The following is a description of a gene set: Genes up-regulated in CD4 T helper cells (4h): Th0 versus TGFB1 and IL6. Despite their enormous importance, the molecular circuits that control the differentiation of Th17 cells remain largely unknown. Recent studies have reconstructed regulatory networks in mammalian cells, but have focused on short-term responses and relied on perturbation approaches that cannot be applied to primary T cells. Here, we develop a systematic strategy – combining transcriptional profiling at high temporal resolution, novel computational algorithms, and innovative nanowire-based tools for performing gene perturbations in primary T cells – to derive and experimentally validate a temporal model of the dynamic regulatory network that controls Th17 differentiation. The network is arranged into two self-reinforcing and mutually antagonistic modules that either suppress or promote Th17 differentiation. The two modules contain 12 novel regulators with no previous implication in Th17 differentiation, which may be essential to maintain the appropriate balance of Th17 and other CD4+ T cell subsets. Overall, our study identifies and validates 39 regulatory factors that are embedded within a comprehensive temporal network and identifies novel drug targets and organizational principles for the differentiation of Th17 cells. from publication Yosef N, Shalek AK, Gaublomme JT, Jin H, Lee Y, Awasthi A, Wu C, Karwacz K, Xiao S, Jorgolli M, Gennert D, Satija R, Shakya A, Lu DY, Trombetta JJ, Pillai MR, Ratcliffe PJ, Coleman ML, Bix M, Tantin D, Park H, Kuchroo VK, Regev A (PMID 23467089) Human Gene Set: GSE43955_TH0_VS_TGFB_IL6_TH17_ACT_CD4_TCELL_4H_UP species: Homo sapiens, and this is the list of marker genes: EIF1AY, PTPN6, SIX1, HFE, RBBP7, MT1E, C8G, RALA, DKK3, PSEN1, NNMT, IL6, AGFG1, OSBPL11 (oxysterol binding protein like 11), MRPL13, RCAN1, IL4R, SEC14L2, LYN (LYN proto-oncogene, Src family tyrosine kinase), CASP8AP2, BTF3, TBC1D10A, GSDME, WDHD1, SAA1, MTMR9, PLA2G4F, CHMP6, HNRNPH2, FBXO21, RNF149 (NCBI Gene Id 284996), SELE (NCBI Gene Id 6401), BIRC3, AKTIP, GBP4, IST1, OMD, PDCD1, ERP44, HNRNPA3, NAA30, FKBP9, CIT, B4GALT3, ADAMTS1, TTC27, GNAQ, MEST, FCGR1A, CD86 (CD86 molecule), PDE8A (NCBI Gene Id 5151), CASK (calcium/calmodulin dependent serine protein kinase), CSF3R, JAK2, MEIS1, TSPAN5, BRWD3, FBXO8, PAG1, NEU1, HEPH, BTG1, RPP21, SEBOX, MCOLN2, POLR1C, CCL4, RPE, ZNF260, MTDH, ZNF146, SAYSD1, TNKS2, PTDSS1, ADSS2, IL2RB, BMPR1B, FAM120A, TARS2, RGS2, CACNA1A (calcium voltage-gated channel subunit alpha1 A), RELB, CXCL9, C5orf34, PSMA3, RPP14, BOLA2, ZZZ3, MLLT1, ITGA4, KCNK3, CLTA, GNG12, TANC1, SGCG, CBX7, EIF4G1, HERC4, GALNT11, TFAP2A, ANP32A, GNAI1, POSTN, EIF2S2, MRPL23, HLX, ZNF436, GADD45G, MYD88, BMP2K, CMTM6, PTGER4, TNFAIP6, UGCG, MAP3K1, PPP1R15A, SOCS3, FKBP1A, HK2, DNAJC9, CEP350, ORC2, PROCR, TGFBI, HDAC2, NADK, PGRMC1 (progesterone receptor membrane component 1), GAR1, NMT1, FDPS (NCBI Gene Id 2224), VAPA, KIF5C, GFI1, SLC7A1, EMC10, ZNF703 (NCBI Gene Id 80139), MAP3K8, MRPL37, THBD, JUNB, SHROOM3, WDR82, SELP, PARD3, CYB5R4, FGL2, BACH1, GJA1, GPR132, CYRIB, TUBGCP3, STK11, SOX11, CEBPD, RHOH, ZFAND5, CHMP7, TBX6, CTSZ, MAP2K1, PARG, B2M, IL1R1, SLC4A7 (NCBI Gene Id 9497), RNASE3, H3-5, PHB2, ADGRG3, LBR, GP9, PTGS2, MT2A, PSMD14, ACTN1, ZFR, DDX3X, TBRG4, SPHK1, IL18BP, SARS1, AATK, CKB, KDM5D, NFIL3, SNX5, EPHA7, CSF2RA, OTULINL, IRF1, ERRFI1, SLC11A1, RPA2, OGFR, EIF6, H1-2, FABP4, MKRN3, SPRED2, CYP2C19, IL15